The following is a description of a gene set: studied in species Homo sapiens The presence of renal cell carcinoma in the renal papilla. Papillary renal cell carcinoma Human Gene Set: HP_PAPILLARY_RENAL_CELL_CARCINOMA, and this is the list of marker genes: MINPP1, MET, LMNA, PRCC, FOXE1, FH, CDC73, HABP2